Given this list of marker genes Adss1, Adprm, Nme1, Txnrd1, Nudt9, Cmpk1, Gart, Impdh2, Ctps1, Entpd5, Rrm2b, Dctd, Pnp2, Ak8, Ampd3, Ada, Nudt5, Ak7, Tymp (NCBI Gene Id 72962), Upb1, Ak6, Ak5, Rrm1, Nt5c, Nudt13, Gda, Gmpr, Cad, Txn1, Guk1, Xdh, Nt5c1a, Entpd3, Ctps2, Paics, Nme3, Tk1, Uckl1, Pudp, Nt5c1b, Entpd7, Adsl, Cda, Uck1, Dguok, Pnp, Nme2, Dck, Upp1, Pfas (phosphoribosylformylglycinamidine synthase (FGAR amidotransferase)), Nudt1, Nudt15, Adal, Nudt18, Nudt16, Gmps, Entpd8, Dpyd (NCBI Gene Id 99586), Nt5c2 (5'-nucleotidase, cytosolic II), Entpd2, Tyms, here is a description of the gene set: Reactome Pathway: Metabolism of nucleotides This event has been computationally inferred from an event that has been demonstrated in another species.<p>The inference is based on the homology mapping from PANTHER. Briefly, reactions for which all involved PhysicalEntities (in input, output and catalyst) have a mapped orthologue/paralogue (for complexes at least 75% of components must have a mapping) are inferred to the other species. studied in species Mus musculus part of: Metabolism electronically inferred by orthology from the curated human pathway